Given this list of marker genes Elavl1, Lig4, Il10, Pole, Rnf20, Pten, Tgfb1, here is a description of the gene set: from publication Motenko H, Neuhauser SB, O'Keefe M, Richardson JE (PMID 26092688) Mouse Gene Set: MP_INCREASED_COLON_ADENOCARCINOMA_INCIDENCE studied in species Mus musculus Mouse genes annotated to increased colon adenocarcinoma incidence (MP:0009314) retrieved from the Mouse Genome Informatics database via MouseMine